Given this list of marker genes CACNG1, BIN1, CACNA1C, NOS1AP, MIR1-1, MIR21, PDE4D, SESTD1, CACNB1, CACNG6, CACNA2D1, PDE4B, NOS1, REM1, CACNB2, CACNB3, APP, CAMK2D, G6PD, NPPA, MIR328, UBR3, here is a description of the gene set: studied in species Homo sapiens Human Gene Set: GOBP_CALCIUM_ION_TRANSMEMBRANE_TRANSPORT_VIA_HIGH_VOLTAGE_GATED_CALCIUM_CHANNEL A process in which a calcium ion is transported from one side of a membrane to the other by means of a high voltage-gated calcium channel.